The following is a description of a gene set: studied in species Homo sapiens Cerebral white matter atrophy The presence of atrophy (wasting) of the cerebral white matter. Human Gene Set: HP_CEREBRAL_WHITE_MATTER_ATROPHY, and this is the list of marker genes: CACNA1E, HACE1, IBA57, MAN2B1, POLR3K, DNM1L, GBA2, MDH2 (malate dehydrogenase 2), DPM2, IDH1, NDUFA8, BCAP31, NFU1, EMC1, ESAM, ALG3, ALG11, FA2H, HYCC1, AIMP1, SLC35A2, HSD17B4, PEX16, ERCC6, CPSF3, ALDH18A1, STXBP1, NSUN3, IRF2BPL, EIF2B4, TTC5, OPA1, SLITRK2, TRAPPC11, MAG, DCX, L2HGDH, CREBBP, IREB2, CSF1R, ATP8A2, COG5, USP7, MYL9, STUB1 (NCBI Gene Id 10387), ATXN2, VPS41, NAXE, PLAA, PHGDH, ASPA, ERCC8, GFM2